Given this list of marker genes IFT43, ZMPSTE24, FLNB, DPYD, IFT122, ATP6V0A2, IHH, SOX9, GPC3, GPC4, WNT10A, NOTCH2, NPR2, B3GALT6, LMNA, here is a description of the gene set: studied in species Homo sapiens Short nail Decreased length of nail. Human Gene Set: HP_SHORT_NAIL